The following is a description of a gene set: Mouse Gene Set: GOBP_NEGATIVE_REGULATION_OF_NF_KAPPAB_TRANSCRIPTION_FACTOR_ACTIVITY studied in species Mus musculus Any process that stops, prevents, or reduces the frequency, rate or extent of the activity of the transcription factor NF-kappaB., and this is the list of marker genes: Lrrc14, Chuk, Ufl1, Ppp2cb, Cmklr1, Irak1, Itch, Nod2, Cdkn2a, Arrb1, Tceal7 (NCBI Gene Id 68496), Usp7, Ikbip, Otulin, Traf3, Psmd10, Havcr2, Rwdd3, Nfkbid (NCBI Gene Id 243910, nuclear factor of kappa light polypeptide gene enhancer in B cells inhibitor, delta), Aim2, Pkhd1, Nlrp12, Brms1, Trim21, Cyld, Foxj1, Cd200, Irak3, Peli1, Bcl3, Zc3h12a, Parp10, Cat, Trim37, Commd1, Erbin, Dab2ip, Tmigd3, Cyp1b1, Cdk5rap3, Tut4, Pycard, Ptgis, Commd7, Nfkbia, Klf4, Spi1, Pias4, Arrb2, Acod1, Anxa4 (annexin A4), Nwd1, Tnfaip3, Mturn, Dap, Sirt1, Prmt2, Trim40, Commd6, Dnaja3, Nlrc3, Gfi1, Setd6, Nlrc5 (NCBI Gene Id 434341), Siva1, Prdx2, Irak2, Traip, Tax1bp1, Chp1, Rbck1, Nr1h4, Cactin, Nfkbil1, Foxp3, Adora3